The following is a description of a gene set: from publication Chen Y, Wang X (PMID 31504780) studied in species Homo sapiens Genes predicted to be targets of miRBase v22 microRNA hsa-miR-6511a-5p in miRDB v6.0 with MirTarget v4 prediction scores > 80 (high confidence targets). Human Gene Set: MIR6511A_5P, and this is the list of marker genes: STMN2 (NCBI Gene Id 11075), MYO1C, WASF2, RCC1L, DESI1, NT5E, RCOR1, ZZZ3, SCUBE3, AKAP6, KCND3, REEP1, CEP350, STOM, MAP3K20, ST8SIA2, ZNF652 (NCBI Gene Id 22834), EVI5, JPH3, KCNT2, LZTS1, FAM83B, MB21D2, GRIK3, BCL11B, MED15, PAPPA, ATP2B3, SPOCK2, MECP2, SIRPB1, PARVB, NUFIP1, BTBD10, ZC2HC1C, UST, EGR2 (early growth response 2), CRIPT, IGFBP3, AFF4, WIPF2, TMEM121B, DUOX1, ME1, NECTIN3 (NCBI Gene Id 25945), ARHGAP1, SERPINB8, ARID1B, TMX3, FIZ1, PLXDC2, HMGXB4, IKZF1, COX15, OLFM2, LIMCH1 (LIM and calponin homology domains 1), IL17A, VAMP7, SUMO3, ZC4H2, STRN, SV2C, RBFOX2, TENT4A, CAMSAP2, NCOA3, ACSL1, SMARCAD1, TF, VPS54, SMIM14, SLC5A9, MAP2, LMBR1L (NCBI Gene Id 55716), ULK2, OSBPL9, NKTR, IPO8, DESI2, ZIC3, ADNP, ERAP1, NECTIN1, ZMAT2, FRAS1, ASAP1, LASP1, HMBOX1, DCP1B, DPF2, ALS2, KIF3B, N4BP1, SV2B (synaptic vesicle glycoprotein 2B), SLC66A1, STIM2, C1GALT1, SMAD2, GPR107, TAF9B, ENSG00000187186, CDKL5, VCL, USP53, SZRD1, PDS5A, SH2B3, FXYD6, SPATA18, C1orf74 (chromosome 1 open reading frame 74), NUP153, FAM8A1, CLEC3A, CRKL, CNOT4, RAB3C, PLXNA2 (NCBI Gene Id 80253), HPCAL4, MBP, CASP7, PAK1, MTF1, RBM39, MYRIP, SPTSSB, RBM3, GOLPH3, FAM91A1, AIF1L, TIAL1, ANKS1B, SERINC5, ZBTB20, KMT2A, DDX50, PLP1, KHDRBS1, KIAA0930, GYS2, TRAF3, AFF3, TECPR2, TNS1, SCML4, ADGRL2, ZFHX2, KPNA3, CCND2, CR1, INHA, MMD, KIF1B, NEXMIF, DPY19L1, ARHGEF6, PPP3CA, BCAS1, SOX6, RNF4, ARRDC4, IGDCC4, SLAIN2, PPP1R3D, PPP1R13L, TMEM154, AMPH, KRT73, CEP85, ANKRD63, ME2, ACAA2, UBAP2, RBMXL1, MYLK3, SLC9A6, APBB2, EML6, CYP8B1, POT1, ATP8A1, MAP3K9, OLFM3, PACS1, USP46, BMP6, CUL5, YWHAB, SRPRA, SETD9, CMTM7, YWHAZ, TTPAL, INHBC, WIPF3, TP53INP2, GSS